The following is a description of a gene set: Any apoptotic process in a dendritic cell, a cell of hematopoietic origin, typically resident in particular tissues, specialized in the uptake, processing, and transport of antigens to lymph nodes for the purpose of stimulating an immune response via T cell activation. studied in species Mus musculus Mouse Gene Set: GOBP_DENDRITIC_CELL_APOPTOTIC_PROCESS, and this is the list of marker genes: Ccl19-ps1, Ccl21a, Cxcl12, Ccl21b, Ccl21d, Ccl19-ps5, Bcl2, Ccl19-ps4, Bcl2l1, Rapgef2, Axl, Ccl19, Nr4a3, Ccl21f, Ccl19-ps3, Jak3, Ccl21e, Lyn, Gas6, Ccl19-ps6